Given this list of marker genes MPC2, PRADC1, IVD, FABP5, RMDN3, GNPAT, SLC5A6, CEBPA, TIMM23, ADAM12, PHB1, GPHN, PRPS1 (NCBI Gene Id 8254), H2AC8, CHP1, UQCR11, MRPL18, RASD1, UQCRH, PPA1, H3C14, ALDOA, MIGA2, FABP4, MYORG, CYCS, CBR3, BCAP31 (NCBI Gene Id 10134), AK2, IFNGR1, NRIP1, CISD1, JAGN1, MRPL15, DBI, HK2, PDIA6, NDUFA8, AIFM1, XBP1 (X-box binding protein 1), LPIN1, GPI, PTGES2, PC, ACADM, CLOCK, ESRRA, MRPL34, CYC1, MRPS26, PPIF, COQ9, ISCA2, MAPK6, ETFB, TOMM40, IGF2 (insulin like growth factor 2), TBL2, PHB2, LMAN2, MRPL20, GINM1, SLC1A5, TOB1 (NCBI Gene Id 10140), SIPA1, RGCC, ORMDL3, COX17, ACO2, TIMM9, G6PD, WFDC21P, TIMM17A, RREB1, GK, PRELID3B, PSMA1, ATP5MK, PRDX3, TMEM97, TYSND1, ABHD5, TIMM8A (translocase of inner mitochondrial membrane 8A), MTX2, ECHS1 (enoyl-CoA hydratase, short chain 1), COX6A1, POR, CRAT, CAVIN1 (caveolae associated protein 1), PPARG, FDX1, PSMA5, GRPEL1, MRPS34, C3, PLA2G12A, NDUFB10, RPP14, MKNK2, TALDO1, RMC1, DNAJB9, SORBS1, SDHD, MRPL12, ACSL1, BCL2L13, C16orf74, PTCD3, MDH2, GYS1, NDUFAB1, PEX14, PEX11A, ATL2, PIM3, MGST3 (microsomal glutathione S-transferase 3), GUCD1, here is a description of the gene set: from publication Burton GR, Nagarajan R, Peterson CA, McGehee RE Jr (PMID 15033539) studied in species Mus musculus Up-regulated at 48-96 h during differentiation of 3T3-L1 cells (fibroblast) into adipocytes. Human Gene Set: BURTON_ADIPOGENESIS_5 During cellular differentiation and development, it is recognized that many complex molecular mechanisms as well as precise patterns of differentially expressed genes occur in directing precursor cells toward a given lineage. Using microarray-based technology, we examined gene expression across the course of 3T3-L1 adipocyte differentiation. Total cellular RNA was isolated at times 0, 2, 8, 16, 24, 48, and 96 h following treatment with either standard hormonal inducers of differentiation; insulin, dexamethasone, isobutylmethylxanthine (IDX), or IDX plus trichostatin A (TsA), a histone deacetylase inhibitor and potent adipogenic inhibitor. cRNA was synthesized from cellular RNA and hybridized to high density Affymetrix MG_U74Av2 microarray gene chips containing 12,488 cDNA/Expressed Sequence Tags (ESTs) probe sets. From the IDX-only treated cells, all probe sets that were either unchanged or differentially expressed less than 2-fold throughout differentiation with respect to time 0 preadipocytes were excluded from further analyses. This selection resulted in a net of 1686 transcripts, 859 were increased in expression, and 827 were decreased in expression at least 2-fold across differentiation. To focus in on genes that were more specific to differentiation, the same analysis was performed on IDX plus TsA-treated non-differentiating cells and all probe sets from the IDX-only group that exhibited similar expression profiles in the non-differentiating TsA-treated group were excluded leaving a total of 1016 transcripts that were regulated only under differentiating conditions. Six hundred and thirty-six of these transcripts were elevated at least 2-fold and 380 exhibited a decrease in expression relative to time 0 preadipocytes. This group of genes was further analyzed using hierarchical clustering and self-organizing maps and resulted in the identification of numerous genes not previously known to be regulated during adipocyte differentiation. Many of these genes may well represent novel adipogenic mediators and markers of adipogenesis.